The following is a description of a gene set: Binding to a macrolide, any of a large group of structurally related antibiotics produced by Streptomyces species. Human Gene Set: GOMF_MACROLIDE_BINDING studied in species Homo sapiens, and this is the list of marker genes: FKBP1A, FKBP1B, FKBP6, FKBP10, FKBP5, FKBP4, FKBP3, FKBP7, LCN2, ALB, FKBP2, NFATC1